Given this list of marker genes Abca1, Prkacb, Apoa1, Prkaca, Bmp1, Zdhhc8, A2m, here is a description of the gene set: HDL assembly species: Mus musculus Mouse Gene Set: REACTOME_HDL_ASSEMBLY